Given this list of marker genes ARHGEF7 (NCBI Gene Id 8874), PXDC1, POGZ, RRS1 (NCBI Gene Id 90810), HEG1, COIL, AURKA, WSB1, TNFAIP8, N4BP1, AMD1, NOP16, ATP13A3, KDM2A, SPOP, PATZ1, BAG5, TRAF4, FOXJ3, SACS, GATA3, KIF2A, KBTBD2, PHF3, DDIT4, RPP38, ADORA2B, ZMYND8, SCHIP1, E2F3, KLF7, SHOC2, TRAM2, TP63, DYRK1A, NEDD4L, TLK1, MCL1, CCN1, BAZ2B, PCDHGB7, FZD2, BRD1, ASAP2, ARL4C, SIAH2, TENT4A, ZNF146, SLC25A44, ADSL, TGIF1, PHC2, HMGA2, CHD1, CASP8, PGRMC2, TIPARP, CDYL, FOXO3, HMGCR, MYC, NUP153, KAT6A, USP32P2, THBD (NCBI Gene Id 7056), RAP1GAP2, EXT1, ID1, BAIAP2, CTCF, ANKRD46, SOX4, JARID2, MPHOSPH10, ERF, DDX3Y (DEAD-box helicase 3 Y-linked), MTF2, TNFRSF1A, NAV3, CSTF1, E2F2, CRKL, SEPTIN8, SLK, MFAP1, BLCAP, CHD8, CNOT2, DUSP4 (dual specificity phosphatase 4), MAST4, MT2A, CENPA, KIFC1, RYBP, TLK2, PUM1, IST1, MARK3, SIAH1, AGO2, FADD, BRD8, TUSC2, RBPJ, WEE1, YTHDF3, PMM2, NGDN, RAPGEF2, IL4R, MORC3, TNFAIP3, ADNP, FOXF2, CNOT4, here is a description of the gene set: To gain insight into the transformation of epidermal cells into squamous carcinoma cells (SCC), we compared the response to ultraviolet B radiation (UVB) of normal human epidermal keratinocytes (NHEK) versus their transformed counterpart, SCC, using biological and molecular profiling. DNA microarray analyses (Affymetrix), approximately genes) indicated that the major group of upregulated genes in keratinocytes fall into three categories: (i). antiapoptotic and cell survival factors, including chemokines of the CXC/CC subfamilies (e.g. IL-8, GRO-1, -2, -3, SCYA20), growth factors (e.g. HB-EGF, CTGF, INSL-4), and proinflammatory mediators (e.g. COX-2, S100A9), (ii). DNA repair-related genes (e.g. GADD45, ERCC, BTG-1, Histones), and (iii). ECM proteases (MMP-1, -10). The major downregulated genes are DeltaNp63 and PUMILIO, two potential markers for the maintenance of keratinocyte stem cells. NHEK were found to be more resistant than SCC to UVB-induced apoptosis and this resistance was mainly because of the protection from cell death by secreted survival factors, since it can be transferred from NHEK to SCC cultures by the conditioned medium. Whereas the response of keratinocytes to UVB involved regulation of key checkpoint genes (p53, MDM2, p21(Cip1), DeltaNp63), as well as antiapoptotic and DNA repair-related genes - no or little regulation of these genes was observed in SCC. The effect of UVB on NHEK and SCC resulted in upregulation of 251 and genes, respectively, and downregulation of genes in NHEK and genes in SCC. To further analyse these changes, we used a novel unsupervised coupled two-way clustering method that allowed the identification of groups of genes that clearly partitioned keratinocytes from SCC, including a group of genes whose constitutive expression levels were similar before UVB. This allowed the identification of discriminating genes not otherwise revealed by simple static comparison in the absence of UVB irradiation. The implication of the changes in gene profile in keratinocytes for epithelial cancer is discussed. species: Homo sapiens from publication Dazard JE, Gal H, Amariglio N, Rechavi G, Domany E, Givol D (PMID 12771951) Human Gene Set: DAZARD_RESPONSE_TO_UV_SCC_DN Genes down-regulated in SCC12B2 cells (squamous cell carcinoma) by UV-B irradiation.